The following is a description of a gene set: species: Mus musculus Mouse Gene Set: GOBP_PRONEPHROS_DEVELOPMENT The process whose specific outcome is the progression of the pronephros over time, from its formation to the mature structure. In mammals, the pronephros is the first of the three embryonic kidneys to be established and exists only transiently. In lower vertebrates such as fish and amphibia, the pronephros is the fully functional embryonic kidney and is indispensable for larval life., and this is the list of marker genes: Lhx1 (NCBI Gene Id 16869), Cep290 (centrosomal protein 290), Osr1, Pax2, Osr2, Sec61a1, Pax8 (paired box 8), Hnf1b